The following is a description of a gene set: The chemical reactions and pathways resulting in the formation of compounds derived from amino acids, organic acids containing one or more amino substituents. species: Homo sapiens Human Gene Set: GOBP_MODIFIED_AMINO_ACID_BIOSYNTHETIC_PROCESS, and this is the list of marker genes: MTHFD1, GGT5, CKMT1A, DHFR2, GATM, SHMT1, GSS, CKB, PLOD3, HAGH, GGT6, FOLR1, ACADM, DHFRP1, FPGS, GGT1, MTHFS (NCBI Gene Id 10588), ATIC, CHAC1 (ChaC glutathione specific gamma-glutamylcyclotransferase 1), PTDSS1, PARK7 (Parkinsonism associated deglycase), PLOD2, GAMT, NFE2L2, SLC46A1, CHAC2, MGST2, BBOX1, GGT3P (NCBI Gene Id 440802), MTHFD1L, TMLHE, GCH1 (GTP cyclohydrolase 1), ALDH7A1, SLC1A1, CKM, SLC7A11, GCLC (NCBI Gene Id 2729), SLC1A2, GCLM, PLSCR1, CKMT1B, GGT7, DHFR, PTDSS2, ALDH9A1, CHDH, CKMT2